The following is a description of a gene set: species: Mus musculus Mouse Gene Set: GOBP_REGULATION_OF_CARDIAC_MUSCLE_TISSUE_DEVELOPMENT Any process that modulates the frequency, rate or extent of cardiac muscle tissue development., and this is the list of marker genes: Fgf3, Erbb3, Creb1, Fgf8, Jph2 (junctophilin 2)